The following is a description of a gene set: part of: Metabolism of water-soluble vitamins and cofactors Reactome Pathway: Molybdenum cofactor biosynthesis Molybdenum cofactor (MoCo) is needed by three enzymes in humans: sulfite oxidase, xanthine oxidase and aldehyde oxidase. The pathway of its synthesis is so conserved that plants and bacteria can readily use human enzymes. Bacteria, however, diverge after the first three steps from this path and their final MoCo differs from that of the eukaryotes. Plants and animals have also developed a refinement of their MoCo which is needed for the function of their xanthine and aldehyde oxidases. This means, in humans we find sulfurated instead of desulfurated molybdenum cofactor on these two enzymes. studied in species Homo sapiens, and this is the list of marker genes: MOCS3, GPHN, MOCOS, MOCS2, NFS1, MOCS1